The following is a description of a gene set: Down-regulated genes from the set C (Fig. 5a): specific to cells expressing AF4-MLL fusion protein alone. Human Gene Set: GAUSSMANN_MLL_AF4_FUSION_TARGETS_C_DN from publication Gaussmann A, Wenger T, Eberle I, Bursen A, Bracharz S, Herr I, Dingermann T, Marschalek R (PMID 17130830) species: Mus musculus The reciprocal chromosomal translocation t(4;11) is correlated with infant, childhood, adult and therapy-related high-risk acute leukemia. Here, we investigated the biological effects of MLL.AF4, AF4.MLL or the combination of both reciprocal fusion proteins in a conditional in vitro cell culture model system. Several parameters like cell growth, cell cycling capacity, apoptotic behavior and growth transformation were investigated under physiological and stress conditions. Co-transfected cells displayed the highest resistance against apoptotic triggers, cell cycling capacity and loss-of-contact inhibition. These analyses were complemented by gene expression profiling experiments and specific gene signatures were established for each of the three cell lines. Interestingly, co-transfected cells strongly upregulate the homeobox gene Nanog. In combination with Oct4, the Nanog homeoprotein is steering maintenance of pluripotency and self-renewal in embryonic stem cells. Transcription of Nanog and other stem cell factors, like Oct4 and Bmi1, was verified in biopsy material of t(4;11) patient cells which express both reciprocal t(4;11) fusion genes. In conclusion, the presence of both reciprocal MLL fusion proteins confers biological properties known from t(4;11) leukemia, suggesting that each of the two fusion proteins contribute specific properties and, in combination, also synergistic effects to the leukemic phenotype., and this is the list of marker genes: SLC7A11 (NCBI Gene Id 23657), IFI16, KLHL4, CCDC7, MLF1, TLE4, PLCL1, ASNS, ERMP1, GREM2, DSCAML1, BCS1L, AHI1, ARHGAP22, UCHL1, IAPP (NCBI Gene Id 3375), NPY1R, ERO1A, CHAC1, CYS1, RNF187